The following is a description of a gene set: Human Gene Set: ONDER_CDH1_SIGNALING_VIA_CTNNB1 studied in species Homo sapiens Genes changed in HMLE cells (mmortalized nontransformed mammary epithelium) after RNAi knockdown of both CDH1 and CTNNB1, compared to the knockdown of CDH1 alone. Loss of the epithelial adhesion molecule E-cadherin is thought to enable metastasis by disrupting intercellular contacts-an early step in metastatic dissemination. To further investigate the molecular basis of this notion, we use two methods to inhibit E-cadherin function that distinguish between E-cadherin's cell-cell adhesion and intracellular signaling functions. Whereas the disruption of cell-cell contacts alone does not enable metastasis, the loss of E-cadherin protein does, through induction of an epithelial-to-mesenchymal transition, invasiveness, and anoikis resistance. We find the E-cadherin binding partner beta-catenin to be necessary, but not sufficient, for induction of these phenotypes. In addition, gene expression analysis shows that E-cadherin loss results in the induction of multiple transcription factors, at least one of which, Twist, is necessary for E-cadherin loss-induced metastasis. These findings indicate that E-cadherin loss in tumors contributes to metastatic dissemination by inducing wide-ranging transcriptional and functional changes. from publication Onder TT, Gupta PB, Mani SA, Yang J, Lander ES, Weinberg RA (PMID 18483246), and this is the list of marker genes: EPAS1, LMCD1, TSPAN13, COL6A3, MIOS, MFAP2, TFRC, GALNT10, NUPR1, SPOCK1, PODXL, TPM1, SEMA3C, TNFAIP3, SERPINE1, NDRG1, CXADR, CXCL1, BIRC3, AGTR1, CD82, ACKR1, LTBP2, CDH11, SCNN1A, PRRX1, EPB41L4B, ARHGAP22 (NCBI Gene Id 58504), VCAN, CCNG2, MLPH, TRBC2, ADRB2, PRUNE2, GREM1, CXCL8, CREG1, SCG5, CREB3L1, CADM3, NREP, KCNMA1, IGFBP3, BEX4 (NCBI Gene Id 56271), CXCL2, MAGEH1, SAA1, LTBP1, PELI1, MYO1B, COL1A2, DOCK10, MICAL2, TAGLN, MYL9, IFIH1, FERMT2, ACTA2, SOX9, ICAM1, PPL, CD83, FZD3, STC2, KDELR3, C3, MMP19, SORL1 (NCBI Gene Id 6653), ERMP1, IGFBP7, AOX1, EPHB2, ANOS1, IL17RC, EFNA1, MAP1B, FBLN5, FBN1, POSTN, SLC46A3, SYBU, BIN1, BGN, KCNJ6